The following is a description of a gene set: Human Gene Set: GSE24492_LYVE_NEG_VS_POS_MACROPHAGE_UP LYVE-1-positive macrophages were observed to be closely spatially associated with the developing lymphatic vasculature. The role of this population of macrophages in the embryo is uncharacterised. We used microarray analyses to investigate which genes are differentially regulated between LYVE-1-positive and LYVE-1-negative macrophages Genes up-regulated in macrophages: LYVE1+ versus LYVE1-. from publication Gordon EJ, Rao S, Pollard JW, Nutt SL, Lang RA, Harvey NL (PMID 20978081) species: Homo sapiens, and this is the list of marker genes: ZBTB3, GPHN, CAMK2N2, TRIP6, EDARADD, FGF13, SUMF2 (sulfatase modifying factor 2), PAK5, CRY2, RC3H1, FBXO42, HAO1, ARSA, OLA1, ORC2, ADGRG3, ZNF213, TEX13B, ACTN2, DNAJB1, STXBP1, STBD1, KDM6B, DNAJC9, MAPK8, POU5F1, CLDND1, MUSTN1, TMEM267, CLYBL, CFAP251, RNF180 (NCBI Gene Id 285671), COL7A1, PML, PGAP6, WBP11, CFAP119, ZIC1, ULK2, SLC6A4, FOXG1, PRR16, ETV6, SOX4, MMACHC, NCKAP5, HIP1, DNAH12, PLEKHA1, MINDY3, KCNIP4, IFTAP, CD40LG, PARP8 (poly(ADP-ribose) polymerase family member 8), RASGEF1A, LTBP4, PCBP3, DNAI1, HDAC10, SLC25A23, GPR83, NKX6-2, PARK7, SDAD1, SPDYA, FBXL2, ITSN1, PIH1D2, RARG, TLCD1, C2CD2L, MTNAP1, PDGFC, TAGAP, BCAP31, GPR84, ZNF410, OLIG1, THSD1, ACACB, NSUN4, KLF12, GREB1, EIF3G, SIRT4, CYTL1, SNAI2, RIPK1, TLR6, PRR5L, TOR1A, HLA-B, TMEM171, CCDC28A, NUDT6, GRIN3A, FAM193A, ZMYM1, TATDN2, CPSF2, XKRX, ST7L, UQCC5, MTRF1L, TMEM69, SLC27A1, PCNT, DNAJC2, CABYR, CXCL11, CXXC5, MDM4, IGIP, SRSF3, VEGFD, CORT, USP36 (ubiquitin specific peptidase 36), LEFTY2, UBA3, RBM12, TSPAN3, KLF6, WNK3, DNAJB6, CP (NCBI Gene Id 1356), STT3B, ZSCAN21, CCDC157, PNMA8B, TLE2, PAX4, EGR3, RILPL1, TEX47, NRP1, SLC25A25, TXNRD3, MAPK8IP2, TTC39C, LMNA, VSIG10, ZNF827, SNX10, IFNA1, EHBP1, SLC41A1, ZNF658, IGSF23, FOXC2, YJEFN3, OTUD1, PRR3 (NCBI Gene Id 80742), CARMIL1, PLEKHG3 (pleckstrin homology and RhoGEF domain containing G3), FAM219A, MYO1E, MUC20, DSN1, SHMT1, FAM163B, FASTKD5, ACAD10, RALGPS2, SBSPON (somatomedin B and thrombospondin type 1 domain containing), FBXO28, SLTM, GPRASP3, CLCNKB, PPP2R2A, PLEKHG5, ARL3, CD7, ZNF473, OGFRL1 (opioid growth factor receptor like 1, NCBI Gene Id 79627), ZNF8, HPDL, BMP7, SLCO3A1, MSANTD1, PROM1, DYNLRB2, ZCCHC8, BRD10, DCTN4, TUSC3, NR2F6, GTF2IRD2, CFAP57, TEKT4, ZSCAN12, PPIC, PBX2, FRK, PABIR1, FOXRED2, UBQLN2 (ubiquilin 2), CRACDL (CRACD like), ENTHD1